The following is a description of a gene set: species: Mus musculus Genes predicted to be targets of miRBase v22 microRNA mmu_miR_7116_5p in miRDB v6.0 with MirTarget v4 prediction scores > 80 (high confidence targets). Mouse Gene Set: MIR_7116_5P from publication Chen Y, Wang X (PMID 31504780), and this is the list of marker genes: Tab2, Car8, Slc30a7, Dvl1, Ube3a, Sorbs1, Henmt1, Mgat4a, Osbpl8, Tspyl4, Ssb, Gpc6, Pcdh7, Caprin1, Napb, Meak7, Cd200r3, Plcl1, Ero1b, Ell, Trim16, Chmp7, Tbc1d23 (TBC1 domain family, member 23), Aga, Cops2, Rptor, Cep350, Rbpjl (NCBI Gene Id 19668), Ripk4, BC107364, Ifit1bl2, AW551984, Irs1, Zfp318, 2010315B03Rik, Rbms3 (RNA binding motif, single stranded interacting protein), Naa30, Ckap4, Camsap1, Neurod4, Fgf23, Adal, Coro2b, Apaf1, P2ry10, St8sia4, Tbc1d4, 9330159F19Rik, Npas3, Atad2, Slc14a1, Rbm25, Pbx1, Sp1, Flvcr1, Parp14, Hcn1, Gpr161, Caps2, Ephb1, Slc8a3, Angpt1, Cited2, Slc38a2, Trim34a, Cpne8, Pakap, Tcf24, Gal3st3, Gtf2a1, Ppp1r9a, Cd244a, Kctd12, Fam210a, Snd1, Tcf4, Ramp1, Sort1, Atg4a, Ccdc122, Tgfbr3, Atp2b2, Ythdf3, Il13ra1, Galnt13, Lypla2 (NCBI Gene Id 26394), Epha8, Uggt1, Nifk, Klhdc3, Fam168a, Smgc, Tmem167, Crtap, Enpp1, Cnot2, Micu2 (NCBI Gene Id 73758), Syvn1, Sel1l, Zfp612, Tmem218, Calhm4 (NCBI Gene Id 270711), Ppp1r14bl, Ube2z, Rftn1, Vps4b, Peg10 (paternally expressed 10), Med14, Rps3, Fam168b, Mpc1, Cep170, Mapkap1 (NCBI Gene Id 99025), Myo5a (NCBI Gene Id 57374), Kcnd3, Ccnc, Trim44, Lsm5, Ptchd4, Slc16a1, Zfp827, Tmprss2, Pex5, Gdap2, Sspn, Lef1, Tmem47, Nrxn1 (neurexin I), Nucks1, Smarca1, Kcnd2, Clasp2, Hlf, Rsbn1, Ptdss1, Ctsc, Klf4, Cd47, Slc45a4 (solute carrier family 45, member 4), Fmo1, Suz12, Apoc3, Ppp1r3d, Ophn1, Gabpa, Adamts12, Rnf141, Ccdc137, Lonrf3, Spopl, Rimoc1, Rcvrn, Col3a1, Satb2, Ermap, Srsf10, Zdhhc2, Ufd1 (NCBI Gene Id 22230), Xk, Csnk1e, En2 (NCBI Gene Id 13799), Ppy, Fyn, Chodl, Magee2, Havcr1, Slc24a5, Strn3, Fnbp4, Lce1c (late cornified envelope 1C), Fgd1, Dcun1d1, Ypel2, Plekhg1 (NCBI Gene Id 52522), Enah, Gm6377, Rab9b, Zwint, Aggf1, Sema3a, Capn12, Rnf144a, Klhl7, Mak16, Itgb8, Reps2, Dtl (denticleless E3 ubiquitin protein ligase), Tram1 (NCBI Gene Id 72265), Reln, Nr2c2, Krtap9-20, AU041133, Wdr36, Wfdc9, Ptprz1, Fcrl1, Rhobtb3, Hspa12a, Hmmr, Rab5if, Serp2, Prune1, Pls3, Plxnb1, Rspry1 (NCBI Gene Id 67610), Ankrd12, Cldnd1, Adam9, Afap1l2, Tacc1, Wdr37, Rras2, Kcnk3, Csmd3, Zmat4, Alcam, 1500009L16Rik, Ar, Pabir2, Tex261, Inppl1, Mapk4, Napg, Pdcl, Frrs1l, Spag17, Sec23b, Plcxd2, Retnlb, Epb41l4a, Dusp6, Api5, Pcdh8, Tm9sf2, Bmi1, Mapk8, Oprk1, Macf1, Krt25, Spty2d1, Ro60, Zfp994, Sash1, Tmed8, Zdhhc3, Myh9 (NCBI Gene Id 97972), Lsamp, Hnf4g, Nae1, Ric3 (NCBI Gene Id 320360), Etv3, Ssbp2